The following is a description of a gene set: Human Gene Set: ARNT_01 Genes having at least one occurrence of the motif NDDNNCACGTGNNNNN in the regions spanning 4 kb centered on their transcription starting sites. This matches the ARNT transcription factor binding site V$ARNT_01 (v7.4 TRANSFAC). species: Homo sapiens, and this is the list of marker genes: NUP62CL, PABPN1, ANKHD1-EIF4EBP3, CHD4, CBX5, HIRA, UBR5 (NCBI Gene Id 51366), CEP83, PLCG2, NTN3, EME1, NEUROD1, UBA1, LEF1, NEUROG2, OGDHL, PDIA2 (protein disulfide isomerase family A member 2), MICU1, TEF, HOXC11, TMEM59L, UTP18 (NCBI Gene Id 51096), RAB3IL1, SRFBP1, KLHL28, LAMP1, HOXD10, CA14, PAK2, MRPL40, DENND6A, PPP1R3C, BRD2, VARS2, NUDC, ARRDC3, AMDHD2, POGK, ABCA1, ZNF711, EIF4B, SPATA2L, TAC1 (NCBI Gene Id 6864), HOXB7, ESRRA, DERL3, SNX5, WASHC4, CD164, CCAR1, EIF3A, ZNF593, IL15RA, REXO2, HNRNPA1, VLDLR, GK, SERBP1, ARMCX6, PRPS1, NR1D1, KDM6A (NCBI Gene Id 7403), AMPD2, RCOR2, CLN3, TOGARAM1, SPPL3, GAPDH, DNTTIP2, EGLN2, BCL11B, DNAJB9, MAP2K6, PSME3IP1, ELAVL3, CSDE1, DNAAF6, CRY2, PCDHA10, TIMM9, UBE4B, SLC39A11, MBNL1, ATP6V1C1, NPTX1, ARF6, STEEP1, SMYD4, PSME3, RMND1, UBXN6, B3GNT9, XPO1, C1orf43, BOK, TXLNG, HOXB4, HOXA7 (NCBI Gene Id 3204), BDNF, ALDH6A1, NEUROD2, AGO2, PPP1R1B, MMP23B, VPS37B, SLC38A5, BEND4, ADAMTS19, ZCCHC7, GTF2H1, ZBTB10, ILF3, DSCAM, ETV4, MNT, HSPD1, COMMD8, ZNF565, PHF20, VGF, ILF3-DT, UBE2B, PLEKHA6, PTMA, ANKRD12, CACUL1, PPAT, PDGFB (NCBI Gene Id 5155), AKAP12, C15orf39, CPEB4, DIP2B, KMT2A, HPS5, HOXB5, RHEBL1, EPB41L4B, RNF128, NMNAT2, CNNM1, DUSP7, MTCH2, FLVCR2, FLT3, COMMD3, GATA5, CARMIL3 (capping protein regulator and myosin 1 linker 3), FGF14, BMP4, DNMT3A, PAICS, KIAA0586 (KIAA0586), DCTN4, FOXF2, NAA50, TTLL11, RLF, LZTS2, SYT6, OBI1, SCRT2, RBBP6, KCNH4, PAX6, RTN4, ATP6V1A, SIRT1, GATA4, IRF9, NKX2-2, UBXN1, LTBR, UBALD1, KAT6A, IGSF22, DVL2, UBXN10, SNX2, CIPC, MMP23A, HOXA11, FXYD6, ATP6V0B, HAPSTR1, KBTBD2 (NCBI Gene Id 25948), TCERG1, ANKHD1, DYM, AP1S2, MGME1, TBC1D5, SYNRG, TMEM132E-DT, ODC1, URI1, MAP7, SYNCRIP, RPA1, SHMT1, QTRT1, HPS3, TGFB2, ZFP91, SNX8, STMN1, IFRD2, VPS16, ZFYVE26, TBC1D15, RPL13A, SLC25A31, RNF44, TRMO, TRPM7, PER1, BHLHE41, FOXD3, CCNYL1, AMMECR1L, SHOC1, SPINK5, RCL1, HOXA1, NRIP3, RALYL, PPRC1, COPS7A, NPM1, AKAP10, TESK2, ADSS2, SYT3, HMGN2, JPH1, PRDM4, AATF, MANF, ARMT1, PICALM, PBRM1, NIT1, TCEAL1, KAT14, EIF4E, PHC3, SNAP25, BMP2K, SLCO1C1 (solute carrier organic anion transporter family member 1C1), BATF3, TFAP4, ETV1, B3GALT6, RSPRY1, PCED1A (NCBI Gene Id 64773), TSKU, ATF7IP, SLC35A5 (NCBI Gene Id 55032), CELSR3, UBR4, STX6, SIGMAR1, EPC1, NDUFA7, MTUS1, NR5A1, ARMCX3, JAG1, TRIM27, SCYL1 (SCY1 like pseudokinase 1), IGF2BP1, DDX3X